The following is a description of a gene set: Curvilinear intracellular accumulation of autofluorescent lipopigment storage material species: Homo sapiens An intracellular accumulation of autofluorescent lipopigment storage material in a curved pattern. Human Gene Set: HP_CURVILINEAR_INTRACELLULAR_ACCUMULATION_OF_AUTOFLUORESCENT_LIPOPIGMENT_STORAGE_MATERIAL, and this is the list of marker genes: NDRG1, CLN6, CLN5, DNAJC5 (NCBI Gene Id 80331), CLN3, TPP1, CLN8